The following is a description of a gene set: studied in species Homo sapiens Any process that modulates the frequency, rate or extent of heart contraction. Heart contraction is the process in which the heart decreases in volume in a characteristic way to propel blood through the body. Human Gene Set: GOBP_REGULATION_OF_HEART_CONTRACTION, and this is the list of marker genes: CHGA, MC3R, TPM1, CHRM2, KCNJ2, ADM2, HSP90AA1, PRKACA, TBX5, CACNA1D, RGS4, MIR208A, TMEM65, MIR133A1, FXYD1 (FXYD domain containing ion transport regulator 1), DRD2, GSTO1, KCNJ12, STC1, GATA4, KCNJ5, SPX, KCNE3, ADM, ATP2A1, KCNN2, CXADR, APLN, GLRX3, TRPC1, PDE4D, MYL2, DSP, ZMPSTE24, GJD3, TGFB2, TMEM38A (NCBI Gene Id 79041), MYL4, AGT, NUP155, SMAD7, TRDN, GJC1, OXT, TMEM161B (NCBI Gene Id 153396), CAV3, ZC3H12A, SREBF1, HSPB7, SUMO1, CACNB2, CASQ2, ASPH, MYBPC3, CELF2, SCN10A, AVPR1A (NCBI Gene Id 552), KCND2, NOS1, ATP1B2, DES, ATP1A3, NMU, NOS1AP, NPPA (natriuretic peptide A), KCNQ1, HOPX, CALM1, PIK3CG, SLC4A3, TNF, TAC1, ADRA1B, KCNE2, HBEGF, GNAO1, S100A1, MIR30E, TNNI3K, NKX2-5 (NCBI Gene Id 1482), ABCC9, EDN3, SCN5A, IRX3, TMIGD3, ATP2B2, ACE2, SLC1A1, MYL3, PDE4B, KCNE5, BIN1, HCN4, RNF207 (ring finger protein 207), GJA1, ADRB1, SLC8A3 (NCBI Gene Id 90450), KCNE1, ATP2B3, SCN4B, HRC, MIR1-1, PTPN1, THRB, IRX5, ATP2A3, PLN, FLNA, FKBP1B, DMD, NOS3, ATP1A1, TNNT2, TNNI3, KCNIP1, MDM2, JPH4, ATP1B1, ADA, ATP1A2, EPAS1, CTNNA3, ACE, MIR328, GCH1, TBX2, ATP2A2, ADORA1, PKP2, THRA, STRIT1, CSRP3, EHD3, TACR3, SRC, HCN1, ISL1, DLG1, ADORA3, KCNH2, SHOX2, HCN3, GRK2, TMEM38B, TBX18, POPDC2, CLIC2, RANGRF, AGTR2, RYR2, JPH2, MIR92A1, GJC3, GLP1R (glucagon like peptide 1 receptor), MYH7, EDN1, MIR19A, CACNA2D1, EDN2, FGF13, HEY2, SNTA1 (syntrophin alpha 1), MEF2A, RNLS, APELA, YWHAE (tyrosine 3-monooxygenase/tryptophan 5-monooxygenase activation protein epsilon), KCNA5, CAV1, BMP10, SRI, JPH1, KCNIP2, SLC9A1, RGS2, EDNRB, CYP2J2, SPTBN4, ADM5, EDNRA, ADRA1A (adrenoceptor alpha 1A, NCBI Gene Id 148), JPH3, SCN3B, DSC2, CACNA1C, MIR448, TRPM4, KCNH6, CALM3, MYH7B (NCBI Gene Id 92771), JUP, TH, KCNJ8, UCN, GSK3A, MYH6, SCN2B, GAA, MIR26A1, KCND3, GPD1L, KCNE4 (potassium voltage-gated channel subfamily E regulatory subunit 4), SLC8A2, CACNA1G (NCBI Gene Id 8913), AKAP9, CALM2, ATP2B1, ADCY10, FKBP1A, CAMK2D, DSG2, BVES, FOXN4, MIR200C, P2RX4, SCN1B, GSTM2, GJA5, SLC8A1, CACNA1H, NPFF, ANK2, KCNJ3, ATP2B4, CORIN, DMPK